Given this list of marker genes BATF, TNF, VTN, FXYD7, HOXB3, LINGO4, BSX, TRPC5, PDE1C, ZDHHC22, EPN3, NR5A1, TFAP2B, KRT1, LRRTM3, ZIC4, MC3R, CNTNAP1, CD72, GALNTL6, PRSS16, RTBDN, VRTN, TMEM100, KCNJ9, LSMEM2, CCDC27, NOL4, FGF14, LRRC4C, ABCA4, THBS2, PCDHB2, UPK3A, TNNC2, SOX6, TMEM119, NKX2-6 (NK2 homeobox 6), SLAMF8, GFI1B, INPP5J, ESRP1, ALPI, RFX4, ESPN, CHST1, KCNG4, CPLX3, DEFB124, NR2F2, ADCY6, CFAP57, CNTNAP2, CXCL10, PAX5, here is a description of the gene set: Genes with intermediate-CpG-density promoters (ICP) bearing the tri-methylation mark at H3K27 (H3K27me3) in MCV8.1 cells (induced pluripotent cells, iPS). Human Gene Set: MIKKELSEN_IPS_ICP_WITH_H3K27ME3 studied in species Mus musculus from publication Mikkelsen TS, Hanna J, Zhang X, Ku M, Wernig M, Schorderet P, Bernstein BE, Jaenisch R, Lander ES, Meissner A (PMID 18509334) Somatic cells can be reprogrammed to a pluripotent state through the ectopic expression of defined transcription factors. Understanding the mechanism and kinetics of this transformation may shed light on the nature of developmental potency and suggest strategies with improved efficiency or safety. Here we report an integrative genomic analysis of reprogramming of mouse fibroblasts and B lymphocytes. Lineage-committed cells show a complex response to the ectopic expression involving induction of genes downstream of individual reprogramming factors. Fully reprogrammed cells show gene expression and epigenetic states that are highly similar to embryonic stem cells. In contrast, stable partially reprogrammed cell lines show reactivation of a distinctive subset of stem-cell-related genes, incomplete repression of lineage-specifying transcription factors, and DNA hypermethylation at pluripotency-related loci. These observations suggest that some cells may become trapped in partially reprogrammed states owing to incomplete repression of transcription factors, and that DNA de-methylation is an inefficient step in the transition to pluripotency. We demonstrate that RNA inhibition of transcription factors can facilitate reprogramming, and that treatment with DNA methyltransferase inhibitors can improve the overall efficiency of the reprogramming process.